The following is a description of a gene set: species: Homo sapiens Genes in the cancer module 73. Human Gene Set: MODULE_73, and this is the list of marker genes: CSF2RB, CXCR4, IL13RA2, TLR2, CXCR5 (NCBI Gene Id 643), TLR1, IL1R1, IL2RG, IL1RL1, IL10RA, IL6R, IL1RAP, IL2RA, IL15RA, IL4R, MYD88, IL1R2, IL7R, CXCR6, IL2RB, CXCR2, IL3RA, IL18R1